The following is a description of a gene set: Genes up-regulated in dendiritic cells from speen: conventional versus plasmacytoid. from publication Chan CW, Crafton E, Fan HN, Flook J, Yoshimura K, Skarica M, Brockstedt D, Dubensky TW, Stins MF, Lanier LL, Pardoll DM, Housseau F (PMID 16444266) studied in species Homo sapiens Human Gene Set: GSE3691_CONVENTIONAL_VS_PLASMACYTOID_DC_SPLEEN_UP To characterize differences between BALB/c splenic CD11cintB220+Gr1+ PDCs (plasmacytoid dendritic cells), CD11cintB220+CD49b+ IKDCs (interferon producing killer-dendritic cells), and CD11chighB220- cDCs (conventional dendritic cells), we performed gene expression profile analysis using Affymetrix chips. We FACS-sorted BALB/c spleen DC subpopulations. Comparison of differentially expressed genes between IKDCs and cDCs vividly revealed selective expression of multiple NK-related genes in IKDCs. These included granzymes A, B, K and M, perforin, Fas ligand, and NK receptors such as NKG2A, NKG2D, Ly49 family genes, NKR-P1, NKG7, NKp46 and Mafa (KLRG1). No NK-related genes were highly expressed in the PDCs., and this is the list of marker genes: FEZ2, VPS37B, CD28, EAPP, CASD1, CTSW, ACKR3, CPOX, MPG, NAPEPLD, GREM1, IMMP1L, NLRP12, MOB3B, HIPK3, TNS4, DAZAP2, SDC1, SRI, ARL4C, RBFA, FAM20A, PRKAG1, ATP10D, FZD1, PLEKHO1, TIAM1 (NCBI Gene Id 7074), GJA1, TRAF3IP3, RAB20, TMEM87A, RAB18, SOS1, VEZF1, PLEKHF2, AAGAB, WASHC2A, MFNG, LONP2, CNP, ARMCX3, SSH2, CYB561A3, DDC, TOR2A, BTG1, TBK1, SNX20, LY6D, PPP2CB, GTF2I, SOX4, PTPRC, TGFB3, SKP1, RORA, MRPS5, B3GNT2, GNGT2, UBE2Q1 (ubiquitin conjugating enzyme E2 Q1), GPRASP2, ZNF655, ADAMTSL4, MAPK9, S1PR1, BCL2L11, SMOX, MAP3K8, UPF2, CANT1, ARHGAP45, TIMP1, ENPP2, ZNF565, LCP1, SLK, PIM1, ULK2, ILVBL, ITPR3, FRMD6, SLC25A19, NXPE3, TNFRSF1A, HIPK2, MAGI3, TSPAN6, OCIAD2, C12orf43, LPXN, FAM217A, DNAJA4, RIPOR2, ABI3, NOB1, MYO3B, OTUB1, MAP3K5, TGFBR2 (NCBI Gene Id 7048), CYLC2, RAPH1, REXO4, CWH43, POU6F1, ZNF777, ARAP2, PPP1R3C, CTSB, DMXL2, MED13L, WDR81, WIPI2, ALKBH4, SESN3, MGLL, SLC9A2, RIN2, TRIB2, PPP1CC, TMEM131 (NCBI Gene Id 55369), N4BP1, ZNF652, RORC, HADHB, ALG5, STN1 (NCBI Gene Id 79991), NDRG3, RBM5, IL21, BIRC3, NLK, GLRX, SEMA6D, MARCHF2, TRPM4, SMAP2, FBXW7, AMACR, GPR18, CRMP1, RNH1, TCF7, ACVR2A (NCBI Gene Id 92), CCL7, TNFRSF25, TXNDC15, ULK1, LAMC2, SBNO2, CYP4F12, PRKCZ, IL17RE (interleukin 17 receptor E), TEX47, PRSS37, STXBP4, CRLF3, EGLN2, FARP2, ASB4, DDI2 (NCBI Gene Id 84301), CLDND1, PSAP, AFTPH, HS3ST6, BAZ2B, CXCR5, SDC3, IL4R, SERPINB1, CCDC73, ATXN10, GRB14, MCOLN2, SLC15A2, UBXN4 (NCBI Gene Id 23190), WDR26, RUNX3, ARHGAP18, ABCA13, FKBP1A, ARAP1, TOP2B, GPR155, CDKN2D, SCRIB, DOCK2, GLCCI1, TENT5C, ATP2A3, MYO6, GPR68, RNFT1, PRG4, POU2AF1, BORCS5 (BLOC-1 related complex subunit 5), CERS4, MARK2, TMEM104, UTS2, CARD6